The following is a description of a gene set: from publication Chen Y, Wang X (PMID 31504780) Mouse Gene Set: MIR_3073A_5P species: Mus musculus Genes predicted to be targets of miRBase v22 microRNA mmu_miR_3073a_5p in miRDB v6.0 with MirTarget v4 prediction scores > 80 (high confidence targets)., and this is the list of marker genes: Ap2m1, Inpp5d, Wnk4, Rnpc3, Bbx, Rc3h2, Dph5, Col25a1, Rmdn1, Smad1, Dkk1, Slc10a4, Ank2, Ogfod1, Ttpal, Ddhd2, Cenph, Slc8a1, Hbp1, Creb3l1 (NCBI Gene Id 26427), Esyt2, Dync1li2, Trim33, Gpatch11, Pced1b, Tbck, 1110004F10Rik, Hpse, Tafa1, Pkdcc, Zfp653, Nus1, Actr3, Nr6a1, Minar2, Prkd1 (NCBI Gene Id 18760), Dynlt3, Kcnc1, Itpripl2 (NCBI Gene Id 330636), Atrx, Rab14, Unkl, Spred1, Faf2, Cacna1b, Ldhb, Tpm3, Idh1 (NCBI Gene Id 98427), Hs3st5, Arpc1a, Tcf12, Sgsm1, Zhx1, Gnat1, Lrguk, Rdh10, Map3k2, Arl2bp, Slx4ip, Ptma, Dmxl2, Scoc, Cyfip2, Abcc1, Yipf4, Rab27b, Poglut1, Cdk8, Rbm4b, Grk6, Ppp6r3, Rgs5, Anxa10, Ubxn7, Stx12 (NCBI Gene Id 100321), En2, Eif5a2, Adamts5, Glrb, Epsti1, Kndc1, Hipk3, Smarca2, Prdm1, Samd10, Smad5, Pml, Nsf, Synpr, Msx3, Csnk1g3, Gls, Sp1, Col1a1, Pkd2, Rabgap1l, Tmem65, Mecp2, Hivep1